The following is a description of a gene set: Mouse Gene Set: GOMF_PROTEIN_TYROSINE_KINASE_ACTIVITY Catalysis of the reaction: ATP + a protein tyrosine = ADP + protein tyrosine phosphate. studied in species Mus musculus, and this is the list of marker genes: Matk, Epha4, Clk4, Ccl5, Insr, Dstyk, Igf2, Eif2ak2, Chka, Fgfrl1, Ttk, Rps6ka5, Ptk6, Fgfr2 (fibroblast growth factor receptor 2), Jak2, Aatk, Hipk4, Dyrk1b, Afap1l2, Fgr, Epha6, Map2k1, Baz1b, Ror1, Zap70 (zeta-chain (TCR) associated protein kinase), Pdgfrb, Lilrb4b, Wee1, Ltk, Musk, Cep43, Erbb2, Htr2a, Txk, Tek, Wee2, Epha7, Stap1 (signal transducing adaptor family member 1), Map2k6, Cav1, Ntrk3, Ptk7, Ret, Igf1r, Ttbk1, Dyrk3, Erbb4, Hbegf, Ephb2, Axl, Alkal2, Flt3, Ngf, Hipk2, Ros1, Tesk1, Peak1, Areg, Dyrk2, Prkcd, Tec, Ttn, Ins1 (insulin I), Abl1, Btc, Map2k3 (mitogen-activated protein kinase kinase 3), Ereg, Melk, Map2k7, Socs3, Nrg2 (neuregulin 2), Lck, Clk3, Eif2ak3, Hipk3, Pdgfra, Epgn, Pak2, Twf1 (NCBI Gene Id 19230), Ddr2, Epha10, Map2k5, Ephb6, Btk, Dyrk1a, Met, Epha8, Hyal2, Mup2, Fgfr3, Ptk2b, Tesk2, Mup11, Ror2, Hck, Styk1, Dusp22, Mup5, Tyro3, Alk, Hipk1, Epha3, Ntrk1, Mst1r, Csk, Syk, Frk (fyn-related kinase), Ephb4, Ins2, Angpt4 (angiopoietin 4), Ptprc, Ryk, Flt1, Erbb3, Tnk1, Egfr, Epha2, Ntrk2, Lyn, Jak1, Mup3, Ephb3, Stk16, Lilrb4a, Pkm, Il6st, Map2k4, Rack1, Ednra, Mup4, Cd24a, Ptk2, Ddr1, Efemp1, Igf1, Tnk2, Map2k2, Mertk, Tyk2, Grm5, Flt4, Dyrk4, Kit, Fes, Ripk2, Srms, Csf1r, Nrp1, Nrp2, Pkdcc, Dgkq, Fgfr4, Insrr, Abl2 (NCBI Gene Id 98214), Mup1, Alkal1, Abi1, Epha1, Ephb1, Clk2, Vegfa, Pbk, Ibtk, Epha5, Kdr, Blk, Nrg1, Src, Fyn, Itk, Jak3, Tgfa, Ghrl, Mtor (NCBI Gene Id 80612), Ahsg, Nek1, Fgfr1, Grem1, Ercc6, Clk1, Egf, Fer, Tie1, Bmx, Yes1 (NCBI Gene Id 22612)